The following is a description of a gene set: Human Gene Set: GOCC_PERIKARYON The portion of the cell soma (neuronal cell body) that excludes the nucleus. studied in species Homo sapiens, and this is the list of marker genes: DMWD, RGS7BP, RGS8, SLC1A1 (NCBI Gene Id 6505), SLC8A3, TMEM266, SLC8A2, ADAM11, RTN4RL2 (NCBI Gene Id 349667, reticulon 4 receptor like 2), KCND2, ERCC8, FZD5, PENK, SYT11, TMEM100, SCN1B, NGFR, GRIK2, APP, KIF5A (NCBI Gene Id 84710), CPNE6, NDN, AZIN2, MAP1B (NCBI Gene Id 4131), MYO1D, DRP2, SYNPO, C9orf72, GIGYF2, EFNA2, RACK1, ATOH7, SEPTIN4, GNRH1, CPNE5, PRPH, KCNA2, EPHA4, NEUROG1, PI4K2A, OPN4, WDFY3, OPRM1, NPFF, ITGA8, RTN4R, NEURL1, FMR1, LRRK2, UBXN2A, FLNA, CLCN2, SLC4A10, KCNB1, DHX36, CIB1, DIP2B, DLG2, ROGDI, TOP1, PTPRS, CPLX1, NSMF, TH (NCBI Gene Id 7054), TTLL7, FYN (NCBI Gene Id 2534), SLC12A5, GAP43, KLHL24, PPP1CA, CPLX2, UCN, RTN4RL1, GRIP1 (glutamate receptor interacting protein 1), DRD2, RUFY3, LRIT3, ZPR1, GLRA1, GLRA3, ASTN1, PDE9A, FCHSD1, LUZP1, KCNH1, KCNA1, CDK5R1, KCNC2, BGLAP, KCNE3, CRHBP, AMIGO1, KCNC3, GRIK3, HPCA, CRMP1 (collapsin response mediator protein 1), NPPA, ASS1, BRD1, SYAP1, CRH, TRPM2, SMN2, CNGA3 (NCBI Gene Id 44), RNF112, KNDC1, CHRNA10, OPRK1, ENDOG (endonuclease G), LYPD6, SLC2A3, NCDN, MAP2K1, ADCYAP1, KCNK1, OLFM1, SMN1, G3BP1 (G3BP stress granule assembly factor 1), ELAVL4, SIRT2, ITGA1, CNR2, SLC17A8, NPY (neuropeptide Y), EPM2A, ASTN2, CTNND2, SORCS2, SEPTIN14, HTR5A, CRYAB, GHRH, NTSR1, CACNA1C, HDAC6, KCNB2, PTPRN, CCR2, SEMA4F, CDK5, SHTN1, ENO2, SLC5A7, MCRS1, CACNA1F, CNTNAP2, TIAM2, PPP5C, SERPINI1, DBNL, PALS1, DDN, RCVRN